The following is a description of a gene set: Protein complex located on the matrix side of the mitochondrial inner membrane and associated with the TIM23 mitochondrial import inner membrane translocase complex ; ATPase motor activity to drive import of proteins into the mitochondrial matrix. species: Mus musculus Mouse Gene Set: GOCC_PAM_COMPLEX_TIM23_ASSOCIATED_IMPORT_MOTOR, and this is the list of marker genes: Grpel2, Grpel1 (GrpE-like 1, mitochondrial), Dnajc15, Dnajc19, Pam16